The following is a description of a gene set: Human Gene Set: GSE34392_ST2_KO_VS_WT_DAY8_LCMV_EFFECTOR_CD8_TCELL_DN Genes down-regulated in P14 CD8+ T cells: ST2 knockout versus wildtype. from publication Bonilla WV, Fröhlich A, Senn K, Kallert S, Fernandez M, Johnson S, Kreutzfeldt M, Hegazy AN, Schrick C, Fallon PG, Klemenz R, Nakae S, Adler H, Merkler D, Löhning M, Pinschewer DD (PMID 22323740) studied in species Homo sapiens Pathogen-associated molecular patterns decisively influence antiviral immune responses, whereas the contribution of endogenous signals of tissue damage, also known as “damage-associated molecular patterns” or “alarmins”, remains ill-defined. We show that interleukin-33 (IL-33), an alarmin released from necrotic cells, is necessary for potent CD8+ T cell (CTL) responses to replicating, prototypic RNA and DNA viruses in mice. IL-33 signaled through its receptor on activated CTLs, enhanced clonal expansion in a MyD88-dependent, CTL-intrinsic fashion, determined polyfunctional effector cell differentiation and was necessary for virus control. Moreover, recombinant IL-33 augmented vaccine-induced CTL responses. Radio-resistant cells of the splenic T cell zone produced IL-33, and efficient CTL responses required IL-33 from radio-resistant cells but not from hematopoietic cells. Thus, alarmin release by radio-resistant cells orchestrates protective antiviral CTL responses., and this is the list of marker genes: UBE2F, NUPR1, RASGEF1B, PPP4R2, RHOB, SLC15A3, TNFSF9, IFIT1, DUSP5, PLXNA2 (NCBI Gene Id 80253), KPNA3, SLC38A4, NFKBIZ, NLRP3, NCOA5, PILRA, SERPINC1, DYRK2, GPR68, RIPK2, ZNFX1, PDGFB, IGSF9, POGK, STX11, TRAF1, TOR3A, NAB2, CCL13, PLPBP, TMEM178A, PCNX1, JAG1, PROCR, PIK3CB, TTC39B, ADRA2B, XCL1, USP18, PARP14 (NCBI Gene Id 54625), SDC1, C3, ATF4, ACSL1, GCH1, GEM, ZNF654, ZHX2, IL2RB, VASN (NCBI Gene Id 337957), BIRC3, JDP2, RAB20, WDR1, GSAP, IFIT2, IRAK3, SWAP70, CMPK2, MTMR14, ARHGAP31, GPC6, LAD1, CXCL2, VASP, HCAR2, EXT1, EDNRB (NCBI Gene Id 3282), FEM1B, SLC5A3, SLC22A5, FABP3, ID2, GRAMD1B, ISG15, IL1B, MARCKSL1, SKIL, NFKB2, RNF11, PDGFA, LRP8, LPAR3, RALGDS, DUSP4, FAS, FPR2, CD86, EDN1, JUNB, GAS7, PCYT1A, PPP1R3B, IL4I1, RASA2, GTF2A1L, BCL2A1, RCAN1, FAM241A, KLF7, NFE2L2, RSAD2, NFKBIE, UAP1, AK2, ZC3H12C, GDF15, CSF1, MALT1, CARD19, ST3GAL1, LONRF1, CD70, PTPRE, CASP4, CLEC5A, STX6, DENND4B, ADAM17, NRP2, EGR2, MED13L, ANXA5, GADD45B, CCL17, EBI3, CLEC6A, FLRT3, IFT57, HTT, FXYD2, ZSWIM4, PLK3, NCF4, NR4A3, JAK2, NR1H3, GPR84, ARHGAP22, TENT5C, SMPDL3B, SRXN1, PLPP3, CCRL2, IL2RG, TLR2, IL6, ALAS1, DUSP1, EGR1, FNDC3B, SAA1, BCL3, MLLT6, SERPINB9, HVCN1, RELB (NCBI Gene Id 5971), IFIT1B, HERPUD1, TAGLN2, SLC2A1, GPD2, MCEMP1 (mast cell expressed membrane protein 1), F3, CEBPB, PSMD10, ARMCX3, MST1, SLC7A8, SLC16A10, PSTPIP2, PLAU, SLC7A2, AGRN, PHLDA1, NLRC5 (NCBI Gene Id 84166), SEMA6D, TMA16, PLEK, RAB30, TMEM26, ATF3, SLC2A6, NFKBID, ICA1L, TGM2, CFLAR, STAP1, UBASH3B, PLEKHO2, MET, TLL1 (tolloid like 1), LATS1, CMTR1 (cap methyltransferase 1), FAM20C, TRAF3, PTPN2, FOSL2, HBEGF, HILPDA